The following is a description of a gene set: species: Mus musculus Mouse Gene Set: GOBP_REGULATION_OF_CELL_CYCLE_PROCESS Any process that modulates a cellular process that is involved in the progression of biochemical and morphological phases and events that occur in a cell during successive cell replication or nuclear replication events., and this is the list of marker genes: Rdx, Fgfr1, Chmp3, Actb, Lsm11, Knl1, Mad1l1, Rpl17, Chmp5, Cdk11b, Myo19, Abraxas1, Cdc42, Kank2, Tgfb1, Klhl22, Ino80, Dact1 (dishevelled-binding antagonist of beta-catenin 1), Spice1, Ooep, Inhba, Clspn, Tacc3, Stil, Spc25, Sin3a, Spc24, Nsfl1c, Mus81, Pdgfb, Nop53 (NCBI Gene Id 98700), Fgf10, Pde3a, Ccng1, Cep120, Mbd4, Aurkb, Stk38, Plk2, Rptor, Mbtps2, Smarcb1, Cd28, Rab11fip4, Zc3h12d, Birc6, Prox1, Cep295, Kifc1, Ppp2r3d, Rrp8, Zfp207, Ccdc66, Nabp2, Ovol1, Fbxo31, Prkcq, Crlf3, Bin1, Csnk2a2, Cdk2ap2, Ube2c, Azin1, Gjc2, Blm, Bcl7a, Wnk1, Klhl21 (kelch-like 21), Ilkap, Rbbp8, Plscr1, Rb1, Rps6ka2, Mlf1, Rps6, Stxbp4, Ccnf, Calm3, Mapk14 (mitogen-activated protein kinase 14), Rcc2, Gigyf2, Klf11, Hmga2, Kat2a, Chmp1b, Tnf, Anapc7, Wnt10b, Mta3, Akt1, Ddb1, Appl2, Pagr1a, Cdc5lrt6, Cdc16, Khdc3, Ttk, Pebp1, Sphk1, Cdkn2c, Fbxo7, Crebbp, Myc, E4f1, Tiprl, Mir124a-2, Vps4b, Cdc5lrt4, Miip, Mcph1, Mapk8, Cetn2, Ncapd3, Actl6a, Hinfp, Mbtps1, Slfn1, Rnf4, Aurka, Prc1, Smpd3, Chtf18, Psma8, Ptpn6, Zfp655, Ppp2r5b, Nek11, Gli1, Cdk2, Rad1, Arid1a, Cdkn2b, Mad2l1bp, Apex1, Atrip, Tipin (NCBI Gene Id 74321), Riok2, Fam107a, Gipc1, Sass6, Foxo4, Lsm10, Aicda, Tas1r2, Anapc2, Rad18, Mnat1, Camk2b, Cdk6, Orc1, Ndc80, Rbm14, Cdca5, Rhoa, H2ax, Chek1, Cdc5lrt9 (NCBI Gene Id 668213), Phf10, App, Fzr1, Tas2r121, Smc5, Clock, Kif13a, Nuf2, Senp2, Gnb1l, Svil, Csf1r, Csnk2a1, Mki67, Smarcd2, Bard1 (BRCA1 associated RING domain 1), Phb2 (NCBI Gene Id 12034), Zwilch, Plk3, Tmod3, Baz1b, Mettl13, Kcnn4, Tgfa, Setmar, Cltc, Dach1, Hspa1b, Cdc5lrt5, Trrap, Cul3, Tfap4, Ankrd17, Dusp1, Rad9b, Usp50, Ticrr, Sh2b1, Cep295nl, Pik3c3, Mir124a-1, Chek2, Cep131, Cenpe, Chordc1, Cdc20, Ccnd2, Kcna5 (potassium voltage-gated channel, shaker-related subfamily, member 5), Tti1, Psmg2, Dcun1d3, Taok2, Rad51c, Ercc2, Sfpq, Tnks, Msx2, Tpr, Ccnq, Rad51b, Bmp4, Wdr62, Vps4a, Apbb1, Mad2l1, BC005624, Chmp1b2, Cenatac, Ins1, Ube2b, Eme2, Pkn2, Kcnh5, Cep192, Npm1, Fen1, Iho1 (interactor of HORMAD1 1), Mir26a-2, Chmp7, Ptpn11, Met, Gper1 (G protein-coupled estrogen receptor 1), Aven, Hspa2, Plcg2, Chmp4c, Sstr5, Sox15, Bora, Tas2r102, Calm2, Atf2, Brcc3, Mrnip, Prap1, Poldip2, Nsmce2, Chfr, Bbs4, Naa10, Trp53, Cxcr5, Spag5, Ercc6, Tpx2, Prpf19, Bcl2l1, Cry1, Poc1b, Cep85, Cdk16, Drg1, Rad51ap1, Prkce, Cdk5 (NCBI Gene Id 12568), Wee2, Grb14, Ythdf2, Donson, Psme1, Gen1, Ereg, Npm2, Psme3, Apc, Dot1l, Zfyve19, Trip13, Prpf4b, Ppp1r10, Fgfr2, Uimc1, Kif11, Atm, Neurog1, Tbx1, Anapc15-ps, Numa1, Rad21, Map10, Ube2e2, Sirt1, Nsun2, Ubxn2b, Usp19, D1Pas1, Sox2, Usp47, Pik3r4, Cdc27, Arf6, Inip, Poc5, Trim37, Edn3, Mn1, Fgf8, Il1b (interleukin 1 beta), Dazl, Six3, Fgfr3, Ccp110, Chmp1a, Larp7, Tbx2 (T-box 2), Trim39, Ing4, Bub1b, Parp9, Kif2c, Rxfp3, Usp28, Tcim, Ect2, Paxip1, Tbx20, Chmp2a, Rrm1, Snd1, Rpa2, Nusap1, Cdk18, Nae1, Kif14, Gpr15lg, Bub1, Bmyc, Wac, Sde2, Cdca8, Rhno1, Eif4g3, Dmrt1, Xpo1, Ctc1, Fbxo43, Men1, Rcc1, Rpl23, Pum2, Plk1, Hormad1, Hacd1, Rgcc, Cdkn1a, Foxn3, Ppp1r35, Rad50, Ints7 (NCBI Gene Id 77065), Lcmt1, Cdk17, Nbn, Pkd2, Brca2, Insm1, Il1a, Klhl18 (kelch-like 18), Zwint, Ncapd2 (NCBI Gene Id 72814), Macroh2a1, Ctnnb1, Cdc14b, Dpf1, Etaa1, Mdm1 (MDM1 nuclear protein), Cdk1, Actl6b, Gpnmb, Fam83d, Rassf1, Smarca4, Prpf40a, Nup62, Drd3, Bcl2, E2f7, Crnn, Xrcc3, Ddx3x, Recql4, Ccsap, Arhgap33os (NCBI Gene Id 381868), Gpr3, Mir26a-1 (NCBI Gene Id 387218), Ncapg2, Becn1, Cdc5lrt8, E2f8, Bmp7, Wnt4, Chmp2b, Adam17, Cenpf, Bid, Arid2, Timeless, Slf1, Rps27l, Sfrp1, Eme1, Mdc1 (NCBI Gene Id 240087), Osm, Rab11a, Racgap1, Cdkn1c, Ddx11, Wiz, Pkp4, Rrm2, Susd2, Ube2u, Znhit1, Appl1, Zfyve26, Pkp3, Smc6, Alms1, Klhl9, Kif20a (NCBI Gene Id 19348), Esr1, Mtbp, Eif4g1, Ccnd1, Msh2, Bcl7b, Dctn1 (dynactin 1), Adamts1, Cep97, Dync1h1, Cdc25c, Ska3, Wee1, Hus1b, Rpl24, Prdm9, D7Ertd443e, Tfdp1, Ctdsp1, Tas2r124, Stk35, Mblac1 (NCBI Gene Id 330216), Msx1, Ccne1, Stra8, Lrp5, Kif20b, Smarca5, Sirt2, Eif2ak4, Fhl1, Mdm2, Sox9, Atf5, Ywhah, Zmpste24, Hyal1 (hyaluronoglucosaminidase 1), Ahctf1, Smarce1, Acvr1, Pdik1l, Ints3, Jade1, Tom1l1, Rmi2, Parp3, Usp44, Gas1, Cdk10, Epgn, Trex1, Paf1, Poc1a, Rab11fip3, Atad5, Taok3, Plpp2, Cit, Cdk15, Apbb3, Ins2, Pdcd6ip, Atxn10, Slf2, Ankrd31, Cep250, Ambra1, Mir26b, Mre11a, Prmt2 (NCBI Gene Id 50502), Klf4, Rbl1, Cyp1a1, Phip, Ccnd3, Ccn2, Insm2, Pcid2, Taok1, Hsf1, Lmnb1, Meiosin, Haspin, Ecd, Brcc3dc, Ccnh, Plcb1, E2f1, Cul7 (cullin 7), Atrx (NCBI Gene Id 67403), Spast, Nubp1, Pdxp, Fsd1, Babam1, Anapc11, Pdgfrb, Gnai1, Aif1, Tmem67, Brca1, Dab2ip, Cspp1 (NCBI Gene Id 72327), Syf2, Cdk5rap3, Anapc5, Ccdc15, Gpr132, Axin2 (axin 2), Pinx1, Mrgprb1, Gpsm2, Chmp4b, Tmsb4x, Cep76, Stox1, Ercc3, Git1, Smarcc1, Diaph3, Cdc5lrt1, Xpc (xeroderma pigmentosum, complementation group C), Brd7, Ncaph, Anapc4, Egf, Cdc5l, Ranbp1, Ctdsp2, Stk33, Ccl12, Usp17le, Rad9a, Hspa1a, Btc, Med1, Aurkc, Cdc14a, Birc5, Pin1, Cdkn1b, Drd2, Cul9, Dgkz, Ccar2, Smarca2, Bub3, Kntc1, Pkia, Ccnb1, Prkdc, Rprd1b (regulation of nuclear pre-mRNA domain containing 1B), Brd4, Ccnb1-ps, Hus1, Ccne2 (cyclin E2), Anxa1, Cdca2, Ik, Pten, Cdk7, Cdc5lrt10, Nme6, Plk4, Cdc7, Pdpn, Anapc15, Kif3b, Lif, Dpf3, Brsk1, Btn2a2, Insr, Mepce, Igf1r, Anp32b, Cenpj, Knstrn, Spdl1, Dna2, Kif23, Rnaseh2b, Calm1, Myo16, Cdc73, Cdk5rap2, Tjp3, Cav2, Pabir1, Fbxo4, Ppp2r2a, Cdkn2d, Dync1li1, Tcf3, Hoxa13, Ppp2r2d, Rad51, Egfr, Setd2, Zfp36l1, Psme2, Cdc5lrt7, Plk5, Smarcc2, Tert, Atr, Sh3glb1, Ska1, Tubg1, Map3k20, Plrg1, Fancd2, Ier3, Ankrd53, Kmt2e, Camk2d, Ankk1 (ankyrin repeat and kinase domain containing 1), Zfp36l2, Psrc1, Rock2, Nabp1, Chmp6, Id2, Incenp, Calr, Kat2b, Dtx3l, Exoc7, Cdk4, Cirbp, Dtl, Map9, Apbb2, L3mbtl1, Txlng, Cdt1, Hnrnpu, Mos, Nuggc, Piwil2, Ctdspl, Topbp1, Rae1, Zfp830, Pbx1, Nfe2l1 (nuclear factor, erythroid derived 2,-like 1), Klhl13, Ddr2, Smarcd3, Trp53bp1, Sgo2a, Ppp2r1a, Gja1, Mark4, Obsl1, Eml3, Pkd1, Fbxo5, Entr1, Pum1, Atp2b4, Smc4, Rad17 (RAD17 checkpoint clamp loader component), Nek2, Cdk3, Rrm2b, Ezh2, H2-M3, Fbxw5, Rint1, Nat10, Nudt16, Pbrm1, Senp6, Cul4a, Wdr76, Ppp2ca, Edn1, Dbf4, Smarcd1, Dpf2, Smc2, Nek6, Igf2, Ubd, Rfwd3 (ring finger and WD repeat domain 3), Pkhd1, Uvrag, Cpsf3, Cacnb4, Trp63, Ptprv, Cep63, Rbl2, Ncaph2, Lef1, Tm4sf5, Cdc23, Nanos2, Dyrk3, Babam2, Bcl7c, Zfy2, Cdc25a, AY074887, Kif2b, Anapc1, Mybbp1a, Kat5, Wnt5a, Creb3l1 (NCBI Gene Id 26427), Usp51, Nek10, Mapk15, Wapl, Npr2, Tex14, Ccnl2, Pkmyt1, Tom1l2, Cdkn2a, Ufl1, Zw10, Cdk14, Ripor2, Cul4b, Cdc25b, Cenpv, Igf1, Ccdc8, Tpra1, Nek1, Lyn, Ccnl1, Cdc6, Hecw2, Dlg1, Fem1b, Mir124a-3